The following is a description of a gene set: studied in species Mus musculus Mouse Gene Set: GOBP_METHYLGLYOXAL_METABOLIC_PROCESS The chemical reactions and pathways involving methylglyoxal, CH3-CO-CHO, the aldehyde of pyruvic acid., and this is the list of marker genes: Park7, Glo1, Haghl, Gatd1, Hagh, Tpi1, Aldoa (aldolase A, fructose-bisphosphate), Pnkd